The following is a description of a gene set: Human Gene Set: GOMF_OXIDOREDUCTASE_ACTIVITY_ACTING_ON_THE_ALDEHYDE_OR_OXO_GROUP_OF_DONORS species: Homo sapiens Catalysis of an oxidation-reduction (redox) reaction in which an aldehyde or ketone (oxo) group acts as a hydrogen or electron donor and reduces a hydrogen or electron acceptor., and this is the list of marker genes: ALDH16A1, DLD (NCBI Gene Id 2654), RDH11, ALDH4A1, ALDH1L1, DLAT, ADH7, PDHA1 (NCBI Gene Id 5160), DHTKD1, PDHA2, ALDH3A2, PDHX, AKR1B1, AKR1C4, ALDH9A1, GAPDH, BCKDHA, HAO1, ALDH1A1, OGDH, GAPDHS, ALDH1L2, FAR2, FAR1, ALDH1B1, ALDH18A1, ALDH5A1, ADH5, ADH4, ALDH1A2, ALDH3B1, ALDH1A3, PDHB, BCKDHB, ALDH3B2, AOX1, AKR1B10, ALDH7A1, ALDH6A1, ALDH2, ALDH8A1, ALDH3A1, OGDHL, AKR1C3, DBT